Given this list of marker genes Psmd5, Psmd2, Psmd4, Psmc4, Psmc5, Psmd10, Psmd9, Psmc1, Psmd1, Psmc3, Psmc2, Psmc6, here is a description of the gene set: species: Mus musculus Mouse Gene Set: GOCC_PROTEASOME_REGULATORY_PARTICLE_BASE_SUBCOMPLEX The subcomplex of the proteasome regulatory particle that directly associates with the proteasome core complex.